Given this list of marker genes IL2RG, SIN3A, CD274, HDAC2, DNMT1, EP300, PRDM1 (NCBI Gene Id 639), HIF1A, STAT3, HDAC1, HDAC3, here is a description of the gene set: Reactome Pathway: STAT3 nuclear events downstream of ALK signaling part of: Signaling by ALK studied in species Homo sapiens Activation of the STAT3 pathway downstream of ALK signaling contributes to cellular survival by modulating expression of a number of genes involved in apoptosis, immune response and angiogenesis. The STAT3 pathway is particularly important in ALK+ cancers that express ALK fusion proteins, where STAT3 contributes to the repression of a number of tumor suppressor genes, highlighting its role as a critical oncogene.